The following is a description of a gene set: Human Gene Set: REACTOME_NEGATIVE_REGULATION_OF_NOTCH4_SIGNALING Negative regulation of NOTCH4 signaling studied in species Homo sapiens, and this is the list of marker genes: PSMB6, SEM1, PSMB7, PSMD11, NOTCH4, PSMA5, PSMD12, ADRM1, RBX1, PSMD8, PSMA1, PSMC1, PSMD3, PSMD6, PSMD14, PSMC4, FBXW7, YWHAZ, PSMC2, PSMC3 (NCBI Gene Id 96121), CUL1, PSMB2, PSMA3, PSMA4, UBB, UBA52, PSMD13, PSMB1, UBC, PSMC6, PSMB3, PSMB5, PSMD1, PSMC5, PSMD7, RPS27A, PSMD2, PSMA6, PSMB4, AKT1, SKP1, PSMA2, PSMA7, TACC3